Given this list of marker genes SLC6A4, HTR1B, CRH, HTR1A, LILRB1, here is a description of the gene set: Human Gene Set: GOBP_REGULATION_OF_SEROTONIN_SECRETION Any process that modulates the frequency, rate or extent of the regulated release of serotonin. studied in species Homo sapiens